The following is a description of a gene set: Mouse Gene Set: GOBP_XENOBIOTIC_CATABOLIC_PROCESS The chemical reactions and pathways resulting in the breakdown of a xenobiotic compound, a compound foreign to the organism exposed to it, carried out by individual cells. It may be synthesized by another organism (like ampicilin) or it can be a synthetic chemical. studied in species Mus musculus, and this is the list of marker genes: Cyp3a41b, Ugt1a1, Cyp3a11, Ugt2b1 (NCBI Gene Id 71773), Gstm6, Cyp2b9, Cyp3a41a, Pon3, Cryz, Cyp2b23, Cyp2b10, Nos1, Cyp2b13, Cyp1a2, Cyp3a44, Gstm1, Gstm5, Gstm4, Acaa1a, Cyp3a16, Gsto1, Acaa1b, Cyp1a1, Nr1i2, Gstm3, Nudt15, Fmo4, Gstm7, Cyp2b19, Acsl1, Gstm2, Abcc2